The following is a description of a gene set: Activation of Matrix Metalloproteinases species: Mus musculus Mouse Gene Set: REACTOME_ACTIVATION_OF_MATRIX_METALLOPROTEINASES, and this is the list of marker genes: Spock3 (NCBI Gene Id 72902), Prss1, Klk1b27, Klk1b22, Cma1, Furin, Mmp2, Mmp1a, Timp2 (tissue inhibitor of metalloproteinase 2), Mmp11, Mmp7, Klk1b5, Ctrb1, Klk1b1, Prss2, Mmp15, Ctsg, Mmp10, Elane, Mmp9, Klk1b4, Tpsb2, Mmp3, Mmp13, Prss3l, Try5, Mmp16, Mmp24, Prss1l, Klk1b9, Mmp14, Prss3, Klk1b8, Ctsl, Klkb1, Klk1, Try4, Timp1, Plg (plasminogen), Klk1b21, Klk1b24, Mmp25, Klk1b3, Col18a1, Mmp17, Klk1b16 (NCBI Gene Id 16615), Try10, Mmp8, Klk1b26, Klk1b11, Ctsk